Given this list of marker genes Ddx17, Bmp4, Nfib, Nfatc4, Tut4, Tert, Nr1h2, Esr1, Drosha, Spi1, Tut7, Tead1, Fos, Snd1, Zswim8, Hras, Mir3960, Bmpr1a, Ago1, Klf4, Ncor1, Elob, Lilrb4a, Smad1, Zfp512b, Hif1a, Agt, Nr3c1, Myc, Ets1, Nr2f1, Dis3l2, Smad3, Tgfb1, Gata4, Smarca4, Myb, Gata2, Tnf, Ep300, Rest, Pparg, Atoh8, Srf, Parn, Notch2, Notch3, Srebf1, Lin28a, Ago2, Apln, Ncor2, Mir744, Gata6, Pnpt1, Rela, Wt1, Pax6, Srebf2, Ppard, Klf5, Ago4, App, Khsrp, Lilrb4b, Mrtfb, Carlr, Mrtfa, Ppara, Myocd, Hdac4, Prl, Tgfb2, Rara, Ctcf, Twist1, Qki, Eloc, Tgfbr1, Bmp2, Foxo3, Fosl1, Tent2, Ar, Stat3, Gata3, Pdgfb, Egr1, Ddx5, Smad6, Nfatc3, Hdac2, Dicer1, Gnl3, Jun, Il10, Yy1, Rc3h1, Tent4b, Smad4, Trp53, Zc3h12a, Sox9, Lin28b, Rc3h2, Nfkb1, Egfr, Bmyc (NCBI Gene Id 99306), Ngfr, here is a description of the gene set: The chemical reactions and pathways involving miRNA, microRNA, a class of single-stranded RNA molecules of about 21-23 nucleotides in length, which regulates gene expression. species: Mus musculus Mouse Gene Set: GOBP_MIRNA_METABOLIC_PROCESS